The following is a description of a gene set: species: Mus musculus Any apoptotic process in a mesenchymal cell. A mesenchymal cell is a loosely associated cell that is part of the connective tissue in an organism. Mesenchymal cells give rise to more mature connective tissue cell types. Mouse Gene Set: GOBP_MESENCHYMAL_CELL_APOPTOTIC_PROCESS, and this is the list of marker genes: Gdf5, Tbx1, Hif1a, Pdcd10, Msx2, Msx1, Dspp, Pou3f4, Sox9, Shh, Hoxa13, Etv6, Pax8, Ednra, Wt1, Hnf1b (HNF1 homeobox B), Pax2, Bmp7